The following is a description of a gene set: Any process that stops, prevents, or reduces the frequency, rate or extent of the import of the hexose monosaccharide glucose into a cell or organelle. studied in species Homo sapiens Human Gene Set: GOBP_NEGATIVE_REGULATION_OF_D_GLUCOSE_IMPORT, and this is the list of marker genes: SIRT6, APPL2, TNF, LEP, GSK3A, STXBP3, PEA15, OSTN, PID1, GRB10, ENPP1, MIR143, CERS1, MIR103A1, MIR107, SELENOS